The following is a description of a gene set: studied in species Mus musculus Any process by which the numbers of cells of a particular type or in a tissue are maintained. Mouse Gene Set: GOBP_MAINTENANCE_OF_CELL_NUMBER, and this is the list of marker genes: Sav1, Selenon, Gnl3, Lsm1, Wdr43, Crxos, Kit, Smarcc1, Obox1, Dsg2, Tuba3b, Pou5f1, Yap1, Igf1, Trp63, Jmjd1c, Yme1l1, Pax8, Igf2bp1, Bcl7c, Tead1, Ncoa3, Ing2, Hesx1, Notch1 (NCBI Gene Id 68125), Arid4b, Jag1, Prox1, Mecom, Rest, Apc, Six2, Bicra, Taf6l, Nfib, Tut4, Cylc1, Eif4enif1, Arid1a, Sfrp1, Padi4, Sinhcaf, Mcph1, Bcl9, Mettl14, Rbbp7, Mir294, Hes5, Nanog, Fancd2, Gsdma3, Ogt, Lbh, Fut10, Esrrb, Sct, Taf5l, Kat2a, Sin3a, Sap130, Zhx2, Foxo1, Cylc2, Sox9, Ing1, Wdr62, Smc5, Mettl3, Paf1, Zic3, Eomes, Raf1, Hook3, Hdac2, Smarcd1, Mmp24, Tead4 (TEA domain family member 4), Ldb1, Ptn, Med24 (mediator complex subunit 24), Cnot1, Brms1l, Bcl7b, Pramel7, Elavl1, Tcl1, Setd6, Erdr1, Nipbl, Stag2, Bcl7a, Loxl2, Cnot2, Prrx1, Kat6a, Rif1, Cul4a, Cdx2, Tcf15 (NCBI Gene Id 21407), Med12, Fgf10, Gata2, Stat3, Hes1, Smarcb1, Rtf1, Fancc, Leo1, Nog, Ss18, Aspm, Ctr9, Tet1, Dll1, Sap30 (NCBI Gene Id 60406), Cdh2, Lrp5 (NCBI Gene Id 16973), Ddx6, Fgfr3, Vps72 (vacuolar protein sorting 72), Wdr47, Med27, Arid4a, Med6, Bcl9l, Sox4, Med21, Mtf2, Kdm3a, Phf10, Med17, Bsx, Eif4e, Phf19, Nkap, Spi1, Sall1, Tcf7l2, Dis3l2, Tcf7l1, Pax2, Fgf4, Braf, Dppa2, Rbpj, Srrt, Hdac1, Crebbp, Suds3, Smc1a, Setd1a, Bmpr1a, Smarce1, Tal1, Med30, Klf10, Actl6b, Zc3h13, Sall4, Rbbp4, Pla2g2a, Miat, Lif, Lrrc46, Wnt9b, Tbx1, Bmp7, Brms1, Actl6a, Ascl2, Trim8, Smarca2, Mapk8, Elf5, Cdc73, Ldb2, Sirt6, Med14, Med28, Kdm2b, Smo, Fgfr1, Brd9, Nr2e1, Dicer1, Tpt1 (NCBI Gene Id 22070), Nodal, Cnot3, Tfap2c, Actb, Zfp706, Smarca4 (SWI/SNF related, matrix associated, actin dependent regulator of chromatin, subfamily a, member 4), Zic1, Pelo, Dpf2, Lig4, Nr5a2, Cfap70, Zfp322a, Hnf1b, Zfp36l2, Kdm4c, Tbx3, Pcm1, Klf4, Sap30l, Vangl2, Lin28a, Tuba3a, Med7, Panct2, Sox2, Tead3, Prdm16, Smc3, Hmga2, Piwil2, Cdkn2a, Ski, Ezh2, Myc, Nanos2, Prdm14, Bicral, Fzd7, Nfix (NCBI Gene Id 18032), Med15, Wnt7a, Foxo3, Med10